Given this list of marker genes OR1J1, OR13C5, OR5D13, TLR4 (toll like receptor 4), SCARB1, OR2AE1, OR5H8, TAS2R60, OR5H2, OR1E2, OR5D14, OR4F21, OR4D5, OR1B1 (olfactory receptor family 1 subfamily B member 1), OR5AC1, TREM2, TAS2R50, OR6V1, OR2V1, OR52R1, OR52I2, OR8U3, KCNMB2, TAS2R45, OR4D11, OR2B8P, OR4A47 (NCBI Gene Id 403253), OR2I1P, OR5T3, OR4C12, OR7G3, REG3A, OR2AP1, ASPH, OR2L3, OR10J1, OR13C2, OR1S2, OR2J2, OR14K1 (olfactory receptor family 14 subfamily K member 1), OR4N2, CST2, OR10G9, OR4C45, OR10A2, CLEC7A, OR52B6, OR6F1, OR2T11, OR8H2, OR5B21, OR4C13, OR56A4, OR1J4, OR56A5, OR5AU1, OR10A6, CST1, KCNIP2, OR4L1, OR5I1, OR2V2, OR52M1, OR52P1, OR5AK3P, OR11H12, OR13C7, OR5H6, GNAT2, OR51E2, OR2T29, OR1F2P (NCBI Gene Id 26745), OR51G1, OR56A1, OR5M8, OR5AN1 (olfactory receptor family 5 subfamily AN member 1), OR4F4, GNAT1, OR5AR1, RTP3, OR11H7, OR1E3, OR2A2, OR14A16, OR4F3, OR2AT4, OR2T27, OR5K4, TLR1, OR52B2, OR4C3, OR5P2, OR1L6, OR2J3, OR2W5P, OR4C6 (NCBI Gene Id 79319), OR10K2, OR13C8, TAS2R41, OR12D1, OR9G9, OR8J3, OR1M1, OR51A7, OR5B17, OR2C1, OR52A5, OR2T3, OR9A1P, RTP2, OR51S1, FFAR4, OR51M1, OR5W2, TLR9, OR6C75, OR4C46, OR51I1, TAS2R8 (NCBI Gene Id 50836), OR4S2, OR10V1, CALM2, OR51H1, OR51A2, CALM1, OR10J6P, OR51F2, OR4C11, TRPA1 (NCBI Gene Id 8989), OR4M2B, OR10Q1, OR4K2, OR6A2, OR2T12, OR12D3, OR1A2 (olfactory receptor family 1 subfamily A member 2), OR7D4, OR5B2, OR52N2, OR5AK2, KCNMB4, OR1D2, OR6J1, OR2T34, OR4A4P, OR5A2, OR2W6P, OR1L4, OR5M3, OR51I2 (NCBI Gene Id 81279), OR11H2, OR51F1, OR6C70, OR3A1, OR2W1, OR7D2, OR2T5, OR4F16, OR8B2 (NCBI Gene Id 26595), OR10G7, OR8S1, OR52K2, OR4A5, OR2M2, OR7E24, OR4D9, OR52H1, TAS1R3, OR3A2, TAS2R46, OR6B1, DRGX, CASQ2, OR2M7, OR2A7, OR8B12, OR2Z1, LBP, OR11H4, OR2G3, OR1F1, OR8B4, OR7A5, OR5T1, SSC5D, OR10A7, OR11H6, OR7A10, OR10G2, OR9Q1, OR1N2, NOD2, TGFB3, OR4D10, OR10J3, OR8H1, OR13D1, OR2L2, OR52I1, OR10H2, OR8B3 (NCBI Gene Id 390271), OR13C9, OR2H1, OR2M3, OR5P3, OR2L13, OR9Q2, OR13G1, SLC24A4 (NCBI Gene Id 56796), OR8U1, OR52A4P, OR4E2, OR8U8, TAS2R42, OR5H14, OR51B5, NR4A1, OR10Z1, OR2B11, LY96 (NCBI Gene Id 23643), OR5G3, OR4D2 (olfactory receptor family 4 subfamily D member 2), OR1F12P, OR2C3, OR52E1, OR1D5, OR4K1, OR14I1, TAS2R9, OR4Q3, OR10A5, OR2T7, OR1Q1, OR14L1, OR2F1, OR2AG2, OR2D3, OR8K5, OR52L1, OR8J2 (NCBI Gene Id 81169), OR6K2, TAS2R20, OR8K3, OR2G6, OR5F1, OR56B1, SLC11A2, OR2M4, OR5M1, OR5H15, OR1A1, P2RX2, OR6C6, GPR148, OR8K1, OR14A2, OR5M11, OR4C5, OR5H1, OR1G1 (NCBI Gene Id 8390), OR4B1, OR6C74, OR2S2, OR4F5, OR1D4, OR5AL1, OR1J2, OR4C16, OR1C1, OR14J1, OR10P1, OR4C15, OR5D16, OR10W1, OR10T2, OR8I2, OR5K2, OR13C4, OR10G6, OR4Q2, OR2A12, OR5V1, OR13C6P, TAS2R39 (taste 2 receptor member 39), OR1N1, OR5A1, OR2A42, OR5M10, OR2B3, OR2T8, OR10C1 (olfactory receptor family 10 subfamily C member 1), PIP, OR6C4, OR7A17, OR13H1, OR2Y1, OR52Z1P, RTP4, OR2T35, OR9I1, OR8G2P, OR5AS1, OR4F6, CYB5R4, OR10AC1, OR2A4, OR2W3, OR4F17, KCNMB1, C4B, OR2B2, OR6K3, OR5C1, OR56B2P, OR52N5, OR2D2, RTP5, TAS2R7, ENG, KCNK3, OR51Q1, CST4, OR2A25, TAS2R1, OR1I1, OR2AG1, OR11A1, OR4A8, OR10H4, OR11G2, OR13C3, TAS1R2, OR8H3, OR52L2P, OR5T2, OR51E1, OR10H3, OR4F15, OR4K14, OR2A1, OR8G5, OR6B3, OR51J1, OR6C3, OR4D1, OR11L1 (NCBI Gene Id 81478), OR3A3, OR12D2, OR5AP2, OR2K2, OR8B8, OR6P1, TAS2R31, PIGR, OR8U9, OR2AJ1, OR10J4, OR13J1 (NCBI Gene Id 81371), OR56B4, OR2T1, OR4M1, OR4F29, OR10D3, OR8A1, OR1L8, OR6C2, OR10J5, OR11H1, CALM3, TAS2R13, OR7A2P, OR10S1, TAS2R5, OR51B4, OR13A1, OR6C1, TAS2R14, OR5K1 (NCBI Gene Id 26339), OR7C2, OR6N1, OR5AC2, PKD2L1, OR8D4, OR9G1, OR1L1, OR10G8, OR1L3, OR2T4, OR6S1, PLCB2, OR2A14, OR10H1, OR4N5, OR5K3, OR4A15, PKD1L3, OR1K1, OR52N1, OR10G4 (olfactory receptor family 10 subfamily G member 4), OR51C1P, OR51A4, TAS2R40, OR2AK2 (NCBI Gene Id 81475), OR2J1, OR8D2, OR6C68, OR52B4, OR2A5, OR51L1, OR13F1, OR8D1, OR4D6, OR52J3, OR2L8, TLR6, OR5B12, OR10R2, OR8G1, OR52K1, OR5D18, OR5BS1P, TAS2R19, OR2M5, TAS2R30, SYT1, OR10A4, OR52N4, OR2T6, OR4E1, OR52A1 (olfactory receptor family 52 subfamily A member 1), OR1E1, OR52W1, OR6T1, TLR2, OR4X1, OR4K15, KCNMB3, OR6Y1, OR2T10, OR1S1, OR10X1, TRPV1, OR9A2, TAS2R16, OR6Q1, OR52D1, OR4K3, OR5J2 (olfactory receptor family 5 subfamily J member 2), OR6C65, OR2T2, OR14C36, OR10G3, OR10D4P, OR8G3P, OR5L2, OR2T33, EXTL3, STIM1, OR4A16 (NCBI Gene Id 81327), OR56A3, OR10H5, OR7C1, TAS2R3, OR10K1, OR6C76, RTP1, OR2F2, OR4M2, OR9A4, OR1P1, RYR2, OR5M9, OR4K5, OR10AG1, OR4X2, OR6X1, TAS2R4, OR7G1, OR51B2, LPO (NCBI Gene Id 4025), OR51B6, CASR, OR10AD1, ASIC3, OR4S1, OR9K2 (NCBI Gene Id 81141), OR4P4, OR52E2, OR6B2, TAS2R43, OR2L5, AZGP1, CA6, OR51G2, OR4N4, OR52E5, OR4K13, OR7G2, OR51T1, OR51V1, OR10A3, OR52E4, OR2H2, TAS2R10, OR2G2, TAS2R38, OR4K17, CNGB1, OR6N2, OR52E8, OR5B3, OR5L1, OR6M1, OR6K6, OR2B6, OR9G4, OR51D1, TAS1R1, SOD2, OR8J1, OR52E6, here is a description of the gene set: studied in species Homo sapiens Human Gene Set: GOBP_DETECTION_OF_CHEMICAL_STIMULUS The series of events in which a chemical stimulus is received by a cell and converted into a molecular signal.